Given this list of marker genes BAZ1B, POGZ, NOVA2, BUD23, CHAMP1, TBL2, MBD5, LIMK1, SMC1A, TBC1D2B, PIDD1, SLC6A17, MECP2, HSD17B10, CDKL5, TMEM106B, PIGS, TREM2, GLI3, VPS37D, GRN, SMARCA2, NCF1, CHMP2B, TYROBP, MED13L, CLIP2 (CAP-Gly domain containing linker protein 2), PGAP1, PRKAR1B, ATRX, WDR4, ADSL, DNAJC30 (NCBI Gene Id 84277), DYRK1A, KANSL1, NTNG2, DCTN1, METTL27, VCP, SLC9A6, GTF2IRD2, STX1A, UBE3A, ELN, OCA2, TTI1 (TELO2 interacting protein 1), SQSTM1, GATAD2B, PSEN1, GTF2I, GTF2IRD1, EIF4H, CSF1R, GABBR2, FKBP6, MAPT, DDX59, TMEM270 (NCBI Gene Id 135886), SNRPN, ATP10A, GRIK2, GM2A, PIGH, RFC2, NTNG1, GRIN1, VPS13A, SRRM2 (NCBI Gene Id 51462), PDE2A, TELO2, here is a description of the gene set: A tendency to violate social norms because of a failure to resist temptations or urges in social settings. species: Homo sapiens Human Gene Set: HP_SOCIAL_DISINHIBITION Social disinhibition